The following is a description of a gene set: studied in species Homo sapiens Human Gene Set: KEGG_MEDICUS_REFERENCE_ORIGIN_UNWINDING_AND_ELONGATION Origin unwinding and elongation. Pathway ID: N01471. Pathway type: Reference. Pathway class: nt06509 DNA replication. Pathway Definition from KEGG: CMG+POLE+MCM10 == POLA+PRIM == RPA -> CMG+MCM10+CTF4+POLA+POLE == RFC+PCNA, and this is the list of marker genes: POLE2, MCM3, GINS1, RPA3, WDHD1, PCNA, PRIM2, RPA1, MCM5, MCM2, GINS4, POLE3, RFC4, GINS3, RFC1, RFC5, MCM10, PRIM1, MCM6, MCM7, POLA2, POLE4, RFC2, POLA1, GINS2, RFC3, MCM4, CDC45, POLE, RPA2